Given this list of marker genes FUCA1, RUNX2, AMER1, SMCHD1, SFRP4, SIX2, here is a description of the gene set: species: Homo sapiens Aplasia or hypoplasia of the paranasal sinuses. Human Gene Set: HP_ABSENT_HYPOPLASTIC_PARANASAL_SINUSES Absent/hypoplastic paranasal sinuses